The following is a description of a gene set: Human Gene Set: REACTOME_ACTIVATION_OF_IRF3_IRF7_MEDIATED_BY_TBK1_IKK_IKBKE Activation of IRF3, IRF7 mediated by TBK1, IKKε (IKBKE) studied in species Homo sapiens, and this is the list of marker genes: RPS27A (NCBI Gene Id 6233), UBC, OPTN, PTPN11, TRAF3, CD14, IKBKE, TBK1, SARM1, UBA52, IRF7, TLR4, TICAM1, UBB, IRF3, LY96, TICAM2, TANK